Given this list of marker genes TMEM183A, GOLIM4 (NCBI Gene Id 27333), EFCAB13, ING3, SDHC, ADGRL3 (NCBI Gene Id 23284), MKLN1, ZNF521, UBASH3B, ADD3, KCNQ3, SEZ6, PCDH7, ITPR3, RBM27, FBXO28, GPATCH2L, SGK1, SIM1, BTBD3, IFRD1 (interferon related developmental regulator 1), STK39 (NCBI Gene Id 27347), USO1 (USO1 vesicle transport factor), FBXO3, ALG10B, GABRG1, WWP1, MYSM1, COMMD8, TRPS1, KRAS, POU4F2, MTMR2, EPHA5, ATF1, APPL1 (NCBI Gene Id 26060), EYS, EIF4G2, IKZF2, KCNJ13, NDST3, UBAP2, ZDHHC23, CA2, PUM1, CHODL, LCA5, DENND1B, FAM221A, C3orf80, MITF, LRRC42, KCNMB2, GCA, SLC9B2, CUL2, LRRN1, TBL1XR1, GCLM, CDKN1B, FMR1, DAB2IP, UBA2, CDC42BPA, PTPN9, CDC27, SH3GL3, SAMD12, MAB21L1, NRK, HP1BP3, AGPS, TAF1A, VSNL1, RAB3GAP2, PGR, ZZZ3, TNFSF13B, ZNF608, TMEM168, GGNBP2, LMO7, SYNE2, CDC14A, PHF14, PPM1B, PDCD4, KLF11, PPFIBP1, FAM13C, TNFSF11, PCYOX1, ACTR3, CENPJ, SLC7A13, SPTLC2, RBBP6, SP8, PRDM11, ZNF148, ASCC3, ROCK2, RBM5, FAM135A, RORA, SMURF1, VAPB, INTS7, ELF1, AFTPH, UBE2K, PRR13, ANKIB1, SNTG1, ZNF90 (zinc finger protein 90), RC3H2, GNAI1, ST7L, TRIM22, PDZRN4, AZIN1, ZDHHC21, IGSF3, TM9SF3, EIF1, FLRT3, NUP43, ENOX1, PLPPR5, PBLD, MSI2, FNIP1, KCNQ5, PTH2R, FNDC3B, C5orf24, ULK2 (unc-51 like autophagy activating kinase 2), ADIPOR1, PDE4B (phosphodiesterase 4B), RAP1GAP2, RAB23, RAPH1, COA1, WDR45B, NPAS3, PRP4K, GAN, LPAR1, EMSY, TMEM183BP, NIPBL, BRI3, SGCE, PTPRK, SYNJ2, SPTY2D1, CHMP5, ELK3, VSTM2A, ATP1B1, SEC23B, PSAT1, HTR2C, KCNB1, LAMC1, TMEM25, EIF1AX, PDCD6IP (NCBI Gene Id 245794), AUTS2, GJB2, MAP3K2, CHIC1, SBNO1, RCN2, TMEFF2, GJA1, TBC1D19, SLC4A7, USP42, GRIA2, CKS2, GAD1, C2orf69, DDX59, MSL3, MAPKAPK5, PCDH8, NPL, CASP8AP2, BRINP1, PNMA2, PBX3, SLC30A7, HNMT, ARF1, CCDC141, PTPN2, TRA2B, WDR36, UBE2Q1, DNAJC6, ZNF506, ARL1, WDR44, FGF14, HIPK1, ATP11A, IL12B, APP, PLPP2, THSD7A, FERMT2, RICTOR, NEK4, ZNF326, IMP3, NFYB, DNAJB6, here is a description of the gene set: Genes predicted to be targets of miRBase v22 microRNA hsa-miR-323a-3p in miRDB v6.0 with MirTarget v4 prediction scores > 80 (high confidence targets). Human Gene Set: MIR323A_3P from publication Chen Y, Wang X (PMID 31504780) studied in species Homo sapiens